The following is a description of a gene set: Mouse Gene Set: GOCC_SARCOLEMMA The outer membrane of a muscle cell, consisting of the plasma membrane, a covering basement membrane (about 100 nm thick and sometimes common to more than one fiber), and the associated loose network of collagen fibers. studied in species Mus musculus, and this is the list of marker genes: Slmap, Scn1b, Kcnj8, Ank1, Adra1b, Popdc2, Lama2 (laminin, alpha 2), Rdx, Dmd, Dlg1, Slc9a1, Esr1, Ednra, Prkcq, Casq1, Oprm1, Nos3, Acp1, Bgn, Agrn, Pld2, Ptk2, Atp1a2 (NCBI Gene Id 98660), Plcb3, Nos1, Camk2d, Itga7, Cacna1s, Cacna2d1, Col6a2, Sync, Ezr, Stac, Itgb1, Stbd1, Cav3, Psen1, Stac2, Scn1a, Anxa2, Sspn, Rem1, Kcnq1, Kcnk2, Smpd4, Sntb1, Cd36, Krt19, Igf1r, Slc8a3, Cavin4, Cib1, Akap6, Slc30a1, Cltc, Sgca, Sgce, Ccdc78, Ank3, Prkg1, Tgfb3 (NCBI Gene Id 21809), Slc38a2, Col6a3, Kcnd2, Ghrhr, Des, Ryr3, Myot, Anxa1, Cacnb1, Fas, Popdc3, Got2, Stac3, Cacnb3, Kcnj2 (potassium inwardly-rectifying channel, subfamily J, member 2), Anxa8, Ncstn, Fkrp, Oprk1, Cd59b, Krt8, Kcnj11, Scn2b, Cacng1, Slc2a5, Kcnd3, Kcnn2, Alox5 (arachidonate 5-lipoxygenase), Ppp3ca, Anxa5 (annexin A5), Obscn, Stx4a, Nos1ap, Tmem151a, Bsg, Capn3, Flot1, Utrn, Atp1a1, Vcl, Anxa6, Trim72, Svil, Msn, Adcy5, Clcn1, Ctsb, Slc2a1, Scn5a, Vdr, Fxyd1, Ank2, Bin1, Dtna, Sntg2, Cib2, Slc8a1, Ppp3r1, Ahnak, Ryr1, Flnc, Sgcz, Pde9a, Kcnj3, Atp1a3, Kcnb1, Slc8b1 (NCBI Gene Id 170756), Pemt, Synm (NCBI Gene Id 73939), Col6a1 (collagen, type VI, alpha 1), Prkar2a (protein kinase, cAMP dependent regulatory, type II alpha), Gnas, Cacna1d, Adra1a, Atp1b1, Snta1, Cacng6, Rtn2, Lamp1, Rrad, Cdh2, Sgcb, Akap7, Fgf6, Alox12, Car4, Slc2a4, Cd59a, Dag1, Abcc8, Sgcd, Aqp4, Slc27a6, Scn2a, Dtnbp1, Ppp3cb, Dst, Prkce, Fgf13 (NCBI Gene Id 14168), Cacna1c, Adrb2, Cacng8, Vcam1, Kcnj12, Atp2b4, Sgcg (NCBI Gene Id 74505), Cacna1h, Sri, Plec, Abcc9, Cacng7 (calcium channel, voltage-dependent, gamma subunit 7), Cacnb2, Bves, Chrm4, Kcnj5 (potassium inwardly-rectifying channel, subfamily J, member 5), Cacng4, Dysf, Pgm5, Mlip, Ryr2, Adcy6, Aqp1, Slc8a2